The following is a description of a gene set: Human Gene Set: GSE21360_NAIVE_VS_QUATERNARY_MEMORY_CD8_TCELL_DN Genes down-regulated inCD8 T cells: naïve versus 4' memory. studied in species Homo sapiens from publication Wirth TC, Xue HH, Rai D, Sabel JT, Bair T, Harty JT, Badovinac VP (PMID 20619696) The transcriptome of naive OT-I T cells was compared to memory CD8 T cells after 1, 2, 3, or 4 infection with ovalbumin expressing Listeria monocytogenes (LM-OVA)., and this is the list of marker genes: LAMP3, PHF11, SP140, IFIT3, APOL6, BZW2, SHFL, CHMP5, TRIM38, RBM22, POGLUT1, PARP12, ESF1, EIF4A1, DOP1A, PPP2R2A, IFITM3, CRK, ZNF134, YEATS2, MIS12, NBN, HERC5, BST2, ODR4, ZNF330, TMEM127, TRAFD1, NGLY1, MORC1, LGALS8, CASP4, KANSL2, KLHL20, TREX1, WNT1, BCL2L14, MOB1A, PALS2, TMEM187, RTP4, PRRC1 (proline rich coiled-coil 1), IFITM1, USP18, ZCCHC2, CNOT8, ZCCHC10, AEN, CDC73, DDX60, OASL, RNF8, FAM98A, HIF1A, PSMA6, MR1 (NCBI Gene Id 3140), MYCBP2, ISG20, DHX58, ADPGK, CUL4A, CHST12, YIPF6, DCP1A, PLSCR2 (NCBI Gene Id 57047), OAS1, XAF1 (XIAP associated factor 1), AARSD1, STAP1, ADAR, NOC3L, IFIH1, GDAP1, NOMO3, ZNF195, SLC16A6, POGK, ANKFY1, LAP3, TRIM22, HNRNPDL, CDC14B, RBM41, IFI27, ZPR1, MTF2, CD69, MX1, VCPKMT, TDRD12, GMPR, NADK, IRF7, TLR3, PML, STAT2, SLC31A1, UBC, NFKBIE, UBE2L6, RIGI, SLC39A14, XIAP, SERPINB9, DDX18, TWNK, IRF8, EIF2S1, KCTD14, TNPO2, RIPK1, FBXW7, CD38, PLSCR1, NMI, ARPC1A, ZNF148, IFI44, ELF1, EIF2AK2, RSRC2, UBE2W, DDX47, MYF6, HERC6, IFI44L, TENT5A, B3GNT2, BCAP29, OAS3, C3orf52, IRF9, EHD4, DENND1A, EIF5, CSNK1G1, SP100, MAIP1, TRIM21, NIP7, NIPAL3, FCHSD2, ZZZ3, H2AC6, CREM, ZNF239, ELOVL6, NSUN3, TDRD7, RASGRP3, INTS12 (integrator complex subunit 12), GTF2B, CMTR1, SRD5A1, MX2, CASP1, LNPEP, DUSP22, NOL8, IFIT5, GOSR1 (golgi SNAP receptor complex member 1), ZNF702P, IFIT2, SP110, ARMCX3, FBXO28, TAP1, NCOA3, DENND1B, N4BP1, TRAPPC4, SNAPC1, PNO1, SLC22A2, COQ10B, TIMM17A, OAS2, LARP1, NIPBL, IFIT1, RSAD2, POLG, BNIP1, MAK16, IFITM2, LAX1, MRTO4, SLC24A1, PSMD11, SETD4, ETV3, SINHCAF, POU2F1, SAMD9, MAD2L1BP, MIS18BP1 (NCBI Gene Id 55320), HOMER1, IFI6, IFI35, ISG15